The following is a description of a gene set: species: Homo sapiens Human Gene Set: WGTTNNNNNAAA_UNKNOWN Genes having at least one occurrence of the highly conserved motif M155 WGTTNNNNNAAA in the regions spanning 4 kb centered on their transcription starting sites. The motif does not match any known transcription factor binding site. from publication Xie X, Lu J, Kulbokas EJ, Golub TR, Mootha V, Lindblad-Toh K, Lander ES, Kellis M (PMID 15735639) Comprehensive identification of all functional elements encoded in the human genome is a fundamental need in biomedical research. Here, we present a comparative analysis of the human, mouse, rat and dog genomes to create a systematic catalogue of common regulatory motifs in promoters and 3' untranslated regions (3' UTRs). The promoter analysis yields 174 candidate motifs, including most previously known transcription-factor binding sites and 105 new motifs. The 3'-UTR analysis yields 106 motifs likely to be involved in post-transcriptional regulation. Nearly one-half are associated with microRNAs (miRNAs), leading to the discovery of many new miRNA genes and their likely target genes. Our results suggest that previous estimates of the number of human miRNA genes were low, and that miRNAs regulate at least 20% of human genes. The overall results provide a systematic view of gene regulation in the human, which will be refined as additional mammalian genomes become available., and this is the list of marker genes: ZNF516-DT, NFYB, AGTR2, ABCC10, S100A10, ESRRG, ENOX1, MPPED2, PAK1IP1, TET2, ADARB2, BCOR, PRDM16, PRSS12, TPPP3, PIK3R1, ZMYND8, FLOT1 (flotillin 1), LUC7L3, TGIF1, XPO1, EMX1, HBS1L, PSMA5, FGF13 (NCBI Gene Id 730528), WBP1L, PPP1R8, GPR85, SP8, CCSER2, THRAP3, KLHL32, PCDH11X, GUCA1C, JARID2, KLHL11, ZNF423, EBF2, EZH2, SPC25, TMTC2, ARHGEF6, CDC42EP4, PRMT3 (NCBI Gene Id 10196), TOX2, CORT, SESTD1, CYP26A1, ZNF485, TFEC, ONECUT2, NEFM, WASF1, EHF, NOG, IL25, CSNK1A1, GBX2, TBCC, RNF34, GATA2, ATP2C1, DTX3L, CRACDL, TRIB1, HIVEP3, LDB1, SH3D21 (NCBI Gene Id 79729), KDM3B, CASK, ERG, KMT2E, FBXW7, KIF13A, MANF, NR4A3, CTDSP1, IGFBP6, CCDC71L, ADGRB3, POC1B, GAD1, FAM53C, RGS3, PRDM13, CYTIP, B3GLCT, ZNF710, PCDH11Y, MYOT, NKX2-8, MOCS1, ZBTB18, BUB3, MAP2K6, KLF3, TMEM131L, ANLN, FAM78A, FEZF2, CRYGB, TEK, SGTB, NR2E1, ZNF362, GRM8, TRDN, ARHGEF12, NR2F2, UBXN10, NLN, AGO2, SLC13A4, RREB1, MXI1, PCSK1, HAND2, SLITRK2, NR2F6, RELCH, MAML3, ZNF521, TFAP2A, ARHGAP30, LPP, CFAP36, DRP2, HOXC4 (NCBI Gene Id 50712), DIPK2B, DDX17, NAP1L5, SP4, DMD (NCBI Gene Id 548327), DCDC1, TSPAN12, RBBP7 (NCBI Gene Id 5931), SH2D1A, DCN, TSPAN16, PRDM1, RIT1, NSD1, HOXD10, COMMD3, CUL7, MGP, PDRG1 (p53 and DNA damage regulated 1), SKAP2, ZNF248, SLC12A8, HOXC6, CSNK1A1L, PEX11A, HNRNPR, PPM1B, VCAN, ALX1, HMGN5, ETS2, VEGFA, LMO3, NRN1L, NXF3, TRIM13, PACRG, EPN3, C1RL, SSTR1, LIMK2, AMMECR1, ARPP21, RHOBTB2, GLS (NCBI Gene Id 51679), DLG2, KLF3-AS1, WNT8B, PITX1, RGS1, ARMCX1, DCP1A, JADE1, PRDM10, SENP6, TFAP2B, ZNF827, NFIB (nuclear factor I B), RDX, TCF4, HOXA9, PHOX2B, ETV1, ROR1, C3orf20, HNRNPA2B1, CREB5 (cAMP responsive element binding protein 5), COL22A1, LDB2, STK38, VAX1, PDZRN4, HCAR2, WNT3, LRRC4 (NCBI Gene Id 85321), ENTPD7, TIAL1, GLIPR2, SOCS2, TIMP2, PARP9, PCDH18, MBNL3, GALNT4, MPC2 (NCBI Gene Id 25874), HCAR3, OXR1, DBNDD2, PRKAG1, ATP5MC3, SART1, FNDC7, KLF5, POMZP3 (POM121 and ZP3 fusion), MMP2, ITPKC, BICD1, GRK2, ZRANB1 (NCBI Gene Id 54764), CDC25A, RPS6KA3, KCNG3, IER3, CFI, FZD7, SEPTIN7, HOXC11, CHD1, ZBTB2, ADCY3, CA5A, MYH1, GAREM1, PCYT2, ODF2, PAX6 (paired box 6), GPBP1, CISH, DGCR8, RASGRP3, KRT84, KLHL13, HOXA3, INHBC, HIVEP1, DMXL1, MED13, SIX5, C1QTNF7, COQ8B, OTX1, MAOA, CXCR4, CCNDBP1, POLA1, PPP4R3B, PRDM12, S100PBP, GLRA2, SYNE2, CHD2, MRPL24, TRMT10A, CA10, UBR3, TEAD2, HMCN1, MGAT4C, ATOH1, PSMD2, HOXC13, MRPL1 (NCBI Gene Id 65008), CYGB, SLC26A7, RUNX1T1, FLRT2, ATXN7L2, BIRC2, PTPRF, PITX2, HOXB4, CEBPB (CCAAT enhancer binding protein beta), ERCC6L2, HLX, DUSP26, RFX3, LINS1, CAPN6, DNAH5, PCDH9, ZHX2, WDR47, FAM180A, MECP2 (NCBI Gene Id 8274), TNFRSF19, RAB43, MITF, H1-10, GCH1, LINC02724, ITGA10, DPF3, HOXB7, MEIS2, TBL1XR1, ABLIM1, FGF12, ADAMTS6, DHX40, SLC20A1, PRKACB, HPSE2, JMJD1C, NRAS, C1orf122, RBMS3, FLI1, YWHAG, NHSL2, CD69, ALK, EDEM3, NPAS2, ZEB2, SSBP2, NDUFB8, MBNL1, CRISP1, WDR93, GSE1, PTP4A1, COL27A1, GYPC, GPR18, HPCAL1, SYT6, RGS13, MAB21L2, AVPR1B, CHST15, BDNF, NAT8, GC, ROGDI, GREB1L, TMEM47, PHEX, LEPROTL1, TGIF2, ST3GAL2, EN1, RXFP1, ZBTB20, UBL5, TMIGD1, FOXA1, PAPLN, RAB3C, SLC4A9, ZNF513, SPIN2A, CC2D2B, IL10, FBXW11, FBXO40, NR4A2, RIN2, TEX2, NOVA1, PRKN, SLC25A18, ATOH8, SLC23A3, PHF8 (PHD finger protein 8), ASIC2, ZKSCAN8, KLF7, NFIA, HNRNPLL, DIPK2A, SRGAP2, SYNE3, STAG2, SLC25A34, FOXP2, SCUBE3, SSBP3, PLPP3, CBX3 (NCBI Gene Id 82756), FGFR1 (fibroblast growth factor receptor 1), THAP11, DENND5A, SIRPA, CREBZF, GPHB5, CHN2, RALY, ZC3HC1, CHML, ZCCHC10, CHD6, NDUFA4L2, ZNF281, DNAJB4, SETD2, MCCC1, SPEF1 (sperm flagellar 1), KCNJ13, PPP2R3A, RHOBTB3, MCAM, RHOQ, SHC3, KCNMA1, YRDC, ASXL1, MARK2 (NCBI Gene Id 2011), NRXN3, BARHL1, TSHB (thyroid stimulating hormone subunit beta), IL17A, PCDH7, BMP4, LGI1, RYBP, NRG1, SRSF7, FOXN3, CPNE1, BCLAF3, BASP1, FOS, FAM27E5, FST, COL9A2 (collagen type IX alpha 2 chain), SLC7A5, DNAJB12, SGIP1, PLXDC2 (NCBI Gene Id 84898), PPP2R5C, ALDH1A3, GNB5, ATP1A2, MPZL3, PDGFB, DHRS3, CD96, IGF1R, CLDN8, BCL6, TMEM263, ZNF407, SREK1, RALYL (RALY RNA binding protein like), NRK, TIMM9, HOXB6, MAP1B, MAP3K4, CDK14, XYLT2, AMBN, NREP, RRM2B, RAPGEFL1, MEOX1, CALN1, BNC2, FNDC3A, CCR7, PPP2R2B, ARL4A, ZNF622 (NCBI Gene Id 90441), PPARGC1B, MAF, LMO4, HOXA11, GARRE1, SLC22A14, CMYA5, LRFN5, GPX1, MARK1, ASTN1, PRPF38A, ETV5, ABCB11, MECOM, OTP, ARHGAP12, SPMIP6, NTF3 (NCBI Gene Id 4908), GRPR, RPA2, ZNF781, ACTR3, CDKN2C, CIMIP6, ZFPM1, FRMD5, GDPD5, MAPK14, CDKN1A, NCAM1, DUSP6, FGF7, GABRA3, BANF2, HOXA5 (homeobox A5), EYA1, EXT1, SHOX2, TMOD4, ORC1, CLVS1, INMT, RASGEF1A, ALB, ADAM11, CTNNA3, PRDX4 (NCBI Gene Id 82852), EPHB1, CLRN1, OGN, COL12A1, CDKL5, TMEM88, KRTAP21-1, HNRNPA0, GPR107, RPSA, SPDEF, SELENOI, NTN5, SRSF6, C2CD2L, CCR1, UBE2E2, HDAC9 (NCBI Gene Id 9734), KIAA0586, OSER1, SRSF2, HS3ST4, CALD1, SGK3, PCBP2, ARG2